Given this list of marker genes DNM1, ACTR1B, AP1S3, RACGAP1, KLC1, SH3GL2, KIF3B, TUBB3, ACTR1A, CTSC, DNM3, KIF11, KIF18A, DYNC1H1, CTSA, KLC2, HLA-DQA1, SAR1B, KIF15, TUBAL3, HLA-DQB1, AP2M1, AP2B1, TUBA4B, KIF5A, AP1M1, SEC24C, CTSE, RILP, KIF3A, KIF5C, CENPE, DYNC1LI2, TUBB2B, TUBB2A, TUBB4B, TUBA3C, SEC24A, KIF20A, AP1M2, KIF2C, AP2A1, HLA-DRB5, KIFAP3, CTSV, HLA-DQB2, DCTN3, CTSO, TUBB6, KIF2A, ARF1, LGMN, CAPZB, HLA-DRA, KIF4B, TUBA3D, CTSD, CTSS, DCTN6, CAPZA2, TUBB1, AP2A2, SEC24B, DYNC1LI1, DCTN5, AP1S2, TUBA4A, HLA-DPB1, DNM2, LAG3, KIF23, AP2S1, TUBB4A, DYNLL1, HLA-DOA (major histocompatibility complex, class II, DO alpha), DCTN2, CTSB, TUBA1B, HLA-DMB (major histocompatibility complex, class II, DM beta), KIF5B, DYNC1I2, CAPZA1, DYNC1I1 (dynein cytoplasmic 1 intermediate chain 1), CD74, KIF3C, KLC3, CAPZA3, SEC24D, CLTC, SPTBN2, TUBA3E, CTSF, TUBB8B, HLA-DQA2, IFI30, HLA-DRB1, HLA-DRB3 (NCBI Gene Id 3125), KIF4A, CTSL, KLC4, SEC31A, HLA-DOB, CLTA, AP1B1, HLA-DMA, TUBA1A, KIF22, TUBB8, CTSH, DCTN4, ACTR10, CTSK (cathepsin K), TUBA8, SEC13, KIF26A, CANX, SEC23A (SEC23 homolog A, COPII coat complex component), DCTN1, RAB7A, OSBPL1A, KIF2B, TUBA1C, AP1S1 (adaptor related protein complex 1 subunit sigma 1), HLA-DRB4, AP1G1, HLA-DPA1, DYNLL2, here is a description of the gene set: part of: Adaptive Immune System studied in species Homo sapiens Antigen presenting cells (APCs) such as B cells, dendritic cells (DCs) and monocytes/macrophages express major histocompatibility complex class II molecules (MHC II) at their surface and present exogenous antigenic peptides to CD4+ T helper cells. CD4+ T cells play a central role in immune protection. On their activation they stimulate differentiation of B cells into antibody-producing B-cell blasts and initiate adaptive immune responses. MHC class II molecules are transmembrane glycoprotein heterodimers of alpha and beta subunits. Newly synthesized MHC II molecules present in the endoplasmic reticulum bind to a chaperone protein called invariant (Ii) chain. The binding of Ii prevents the premature binding of self antigens to the nascent MHC molecules in the ER and also guides MHC molecules to endocytic compartments. In the acidic endosomal environment, Ii is degraded in a stepwise manner, ultimately to free the class II peptide-binding groove for loading of antigenic peptides. Exogenous antigens are internalized by the APC by receptor mediated endocytosis, phagocytosis or pinocytosis into endocytic compartments of MHC class II positive cells, where engulfed antigens are degraded in a low pH environment by multiple acidic proteases, generating MHC class II epitopes. Antigenic peptides are then loaded into the class II ligand-binding groove. The resulting class II peptide complexes then move to the cell surface, where they are scanned by CD4+ T cells for specific recognition (Berger & Roche 2009, Zhou & Blum 2004, Watts 2004, Landsverk et al. 2009). Reactome Pathway: MHC class II antigen presentation